Given this list of marker genes ATM, RNF138, SPO11, SLX1B, HELQ, DNA2 (DNA replication helicase/nuclease 2), SMARCAD1, BLM (NCBI Gene Id 641), BRIP1, RAD52, HELB, C14orf39, NBN, SLX4, RAD50, UBE2V2, RBBP8, MRE11, UBE2N, EXD2, SLX1A, SETMAR, here is a description of the gene set: studied in species Homo sapiens The 5' to 3' exonucleolytic resection of the DNA at the site of the break to form a 3' single-strand DNA overhang. Human Gene Set: GOBP_DNA_DOUBLE_STRAND_BREAK_PROCESSING